Given this list of marker genes TIMP1, CALR, ARHGDIB, ACVR1C, GJA1, NODAL, MIR16-1, MIR15B, here is a description of the gene set: Any process that stops, prevents or reduces the frequency, rate or extent of trophoblast cell migration. studied in species Homo sapiens Human Gene Set: GOBP_NEGATIVE_REGULATION_OF_TROPHOBLAST_CELL_MIGRATION